The following is a description of a gene set: Retinal pigment epithelial mottling Mottling (spots or blotches with different shades) of the retinal pigment epithelium, i.e., localized or generalized fundal pigment granularity associated with processes at the level of the retinal pigment epithelium. Human Gene Set: HP_RETINAL_PIGMENT_EPITHELIAL_MOTTLING species: Homo sapiens, and this is the list of marker genes: MT-ATP6, PITPNM3, CNNM4, EFEMP1, RPGR, PROM1, SPATA7, SLC6A6, NBN, TWNK, CYP4V2, RPE65, ELOVL4, CFAP410, CTNS, ATF6, CNGA3, PDE6H, CHM, GPR143, CACNA2D4, GUCA1A, GUCY2D, PDE6C, LRAT, GNAT2, TUBB4B, ABCA4, CLCN3, RLBP1, CFI, LCA5, PEX1, RDH5, SELENOI, ERCC8, PISD, DHX16, RPGRIP1, POLG, NMNAT1, PRPH2, VPS41, CFH, CNGB3, ALDH6A1, RHO, IFT52